The following is a description of a gene set: part of: Unfolded Protein Response (UPR) Reactome Pathway: PERK regulates gene expression PERK (EIF2AK3) is a single-pass transmembrane protein located in the endoplasmic reticulum (ER) membrane such that the N-terminus of PERK is luminal and the C-terminus is cytosolic. PERK is maintained in an inactive form by interaction of its luminal domain with BiP, an ER chaperone. BiP also binds unfolded proteins and so BiP dissociates from PERK when unfolded proteins accumulate in the ER. Dissociated PERK monomers spontaneously form homodimers and the homodimeric form of PERK possesses kinase activity in its cytosolic C-terminal domain. The kinase specifically phosphorylates the translation factor eIF2alpha at Ser52, resulting in an arrest of translation. Thus translation of proteins targeted to the ER is downregulated. The translation arrest also causes depletion of Cyclin D1, a rapidly turned over protein. The depletion of Cyclin D1 in turn causes arrest of the cell cycle in G1 phase. species: Homo sapiens, and this is the list of marker genes: EXOSC4, HSPA5, NFYA, ATF4, EIF2S1, EIF2S3 (NCBI Gene Id 8422), EXOSC5, HERPUD1, DIS3 (NCBI Gene Id 22894), NFYC, ASNS, EXOSC8, IGFBP1, EXOSC3, ATF6, ATF3, CEBPG, CEBPB, CXCL8 (NCBI Gene Id 3576), EXOSC1, NFYB, EXOSC6, DDIT3, EIF2S2, EXOSC2, CCL2, KHSRP, PARN, EXOSC9, EXOSC7, DCP2 (NCBI Gene Id 167227), EIF2AK3